The following is a description of a gene set: The lipid bilayer surrounding an endolysosome. An endolysosome is a transient hybrid organelle formed by fusion of a late endosome with a lysosome. studied in species Homo sapiens Human Gene Set: GOCC_ENDOLYSOSOME_MEMBRANE, and this is the list of marker genes: ABCB6, PCSK9, TASL, CLTA, TLR3, TPCN2, TLR9 (toll like receptor 9), AP2S1, ATG16L1, AP2M1, SLC15A4, LDLR, AP2A1, CLTC, RNF167, AP2A2, AP2B1, TLR7, TLR8